The following is a description of a gene set: Reuptake of GABA from the synapse terminates the action of GABA thus regulating GABA action. GABA taken up from the synapse into the neurons is reused for synaptic loading. GABA taken up by astrocytes is degraded into C02 and glutamine. Glutamine is transported into the neurons for glutamate and GABA synthesis. part of: GABA synthesis, release, reuptake and degradation studied in species Homo sapiens Reactome Pathway: Reuptake of GABA, and this is the list of marker genes: SLC6A1, SLC6A11, SLC6A12, SLC6A13